The following is a description of a gene set: species: Homo sapiens Abnormal circulating aldosterone concentration Human Gene Set: HP_ABNORMAL_CIRCULATING_ALDOSTERONE_CONCENTRATION, and this is the list of marker genes: SCNN1A, ARMC5, CDKN1A, CACNA1H, CACNA1D, CYP17A1, SCNN1G, SCNN1B, ZNRF3, AIRE, CLCN2, CYP11A1, CTNNB1, KCNJ10, MC2R, CLCNKB, PRKAR1A, TXNRD2, GNAS, CDKN2B, NR0B1, SLC26A3, CYP11B2, AAAS, CDKN2C, TERT, INSR, MRAP, STAR, KCNJ1, AVPR2, CLCNKA, NR3C2, TRAPPC11, NR3C1, CYP11B1, NNT, HSD3B2, KCNJ16, OCRL, HSD11B2, KCNJ5, MEN1, CDKN2A, BSND, SEC61A1, GMPPA, CDKN1B, SLC12A1, KDM1A, KCNJ2, TP53, SLC12A3